Given this list of marker genes MARCHF10, GNB2, ELP4, TSKU, NCALD, SPARC, ABHD14A, PPT2, NLGN2, PCDHB1, PLEC, PCF11, SHANK2-AS3, AGPAT4, PTMS, TRDMT1, PLP2, SYT5, BLZF1, FXYD7, DNAJA1, CHD5 (NCBI Gene Id 26139), TMEM95, CDK2AP2, SH3GLB2, KCNIP2, INO80B, TM9SF1, ATP13A4, RFX4, SEMA4B, KCNIP4, STAT5B, STRN4, DNAAF6, CFAP298, INTS3, DMTN, ARL6, CALY, CINP, BTBD3, ELMO1, PRRT1, NUP62CL, ELAVL4, FSIP1, TMTC2, SPATA2, MORN4, FANK1, RHOBTB2, CADM1, TP53BP1, NSMF, LMAN2L, ZDHHC1, ANKFN1, TUBB4A, CDK9, UVRAG, CAMK1, THNSL1, STOML2, ERG28, ENKUR, CFAP57, RHOBTB1, CFAP20DC, CNIH2, GLA, FKRP (NCBI Gene Id 79147), B9D2, CAMK2A, FPGT, ZP1, ATP6V1C2, MAPK10, MPP2, MORF4L2, ORAI3, CEP135, ATN1, B9D1, FXYD6, SPAG16, HYDIN, RPP38-DT, USF1, RALYL, LRRC25, NRSN2, QRFP, ZFYVE1, ING2, NHERF1, EDC4, IMMP1L (NCBI Gene Id 196294), STX18, LRRIQ3, HNRNPH2, NME7, KCNJ9, SPTB, MINK1, GRM1, GRHL2, TRMT9B, EBNA1BP2, RPP38, PUM1, here is a description of the gene set: Human Gene Set: GTTGNYNNRGNAAC_UNKNOWN Genes having at least one occurrence of the highly conserved motif M43 GTTGNYNNRGNAAC in the regions spanning 4 kb centered on their transcription starting sites. The motif does not match any known transcription factor binding site. from publication Xie X, Lu J, Kulbokas EJ, Golub TR, Mootha V, Lindblad-Toh K, Lander ES, Kellis M (PMID 15735639) Comprehensive identification of all functional elements encoded in the human genome is a fundamental need in biomedical research. Here, we present a comparative analysis of the human, mouse, rat and dog genomes to create a systematic catalogue of common regulatory motifs in promoters and 3' untranslated regions (3' UTRs). The promoter analysis yields 174 candidate motifs, including most previously known transcription-factor binding sites and 105 new motifs. The 3'-UTR analysis yields 106 motifs likely to be involved in post-transcriptional regulation. Nearly one-half are associated with microRNAs (miRNAs), leading to the discovery of many new miRNA genes and their likely target genes. Our results suggest that previous estimates of the number of human miRNA genes were low, and that miRNAs regulate at least 20% of human genes. The overall results provide a systematic view of gene regulation in the human, which will be refined as additional mammalian genomes become available. species: Homo sapiens